Given this list of marker genes CASZ1, BAGE2, ARFGEF1, CXCL12 (C-X-C motif chemokine ligand 12), KIF13A, MMP16 (NCBI Gene Id 84257), TMPO, IMPDH1, YAP1, BTBD7, SLC35F1, PLD5, SATB2, PANX3, MYO1A, WWP2, MEIS2, REEP3, CARMIL1, TKTL2, PLEKHG7, KCNE4, FUT9, RHEBL1, PTPRB, RFX7, ITSN2, MBNL1, ARHGEF38, CSMD3, ONECUT2, SHANK1, YES1, LRRC8A, PRKCI, MBD5, NUFIP2, HBP1, IRX4, AKAP10, RNF19B, CDYL, GARRE1, SLC35F3, MBD6, PRMT3, SYNPO2, SLC2A13, ADIPOR1, ARL15, WDR45B, here is a description of the gene set: from publication Chen Y, Wang X (PMID 31504780) Genes predicted to be targets of miRBase v22 microRNA hsa-miR-648 in miRDB v6.0 with MirTarget v4 prediction scores > 80 (high confidence targets). studied in species Homo sapiens Human Gene Set: MIR648